The following is a description of a gene set: Binding to activin, a dimer of inhibin-beta subunits. Mouse Gene Set: GOMF_ACTIVIN_BINDING species: Mus musculus, and this is the list of marker genes: Tgfbr1, Acvr1, Acvr1b (NCBI Gene Id 328611), Tgfbr2, Tgfbr3 (NCBI Gene Id 73753), Acvr2a, Acvr2b, Fst, Acvrl1, Acvr1c (activin A receptor, type IC), Fstl3